The following is a description of a gene set: Catalysis of the reaction: O2 + reduced + testosterone = 16beta,17beta-dihydroxyandrost-4-en-3-one + H+ + H2O + oxidized. Mouse Gene Set: GOMF_TESTOSTERONE_16_BETA_HYDROXYLASE_ACTIVITY species: Mus musculus, and this is the list of marker genes: Cyp2b13, Cyp2b23, Cyp2b19, Cyp46a1, Cyp2b10, Cyp2b9 (NCBI Gene Id 13094)